Given this list of marker genes KRT9, KRT16, EGFR, DSC3, CYP4F22, KIF11, CARD14, XYLT2, TGM1, LORICRIN, IL1RN, PERP, CARMIL2, KDSR, GJA1, MPV17, ALOXE3, COL14A1, MBTPS2, ALOX12B, LMNA, KRT1, POGLUT1, CAST, ELOVL1, RNF168, GNB2, DSG1, WNT10A, IL7R, EBP, ELOVL4, SLURP1, AKT1, TUFT1, ZMPSTE24, FLG, PPP2R3C, LRBA, HLA-B, DSP, ZNF750, JUP, ENPP1, LRP1, KIT, AAGAB, SAMHD1, CYP26C1, LIPN, SASH1, NSDHL, ATP2A2, SERPINB8, FERMT1, IL36RN, CSTA, NLRP1, PKP1, IKZF1, ATP2C1, MPDU1, CASP14, SLC27A4, CIB1, ABCC6, ADAM17, SMARCAD1, CERS3, CDSN, KRT2, KRT10, GJB2, KRT74, KLK11, FLG2, SERPINB7, NIPAL4, RECQL, GRHL2, LDHA, KRT13, SULT2B1, ECM1, CLDN1, OSMR, RIGI, GJB3 (gap junction protein beta 3), TGM5, KRT6C, GJB6, EXPH5, XYLT1 (NCBI Gene Id 64131), IL2RA, RASA1, here is a description of the gene set: Human Gene Set: HP_ABNORMAL_EPIDERMAL_MORPHOLOGY An abnormality of the morphology of the epidermis. species: Homo sapiens Abnormal epidermal morphology